Given this list of marker genes PPP1R1B, LINC02038, FGF20, SFTPA2, PGC, NOTUM, SFTPA1, LINC01331, ENG, CLDN2, AQP1, ADH1C, C11orf96, C10orf90, RASGRF1, CEMIP, DLG2, FMN1, KCNJ5, CDH16, SHISA2, CD36, MGLL, TMEM163, ADORA1, NAPSA, TNC, COL6A3, ASPG, ACOXL, C16orf74, here is a description of the gene set: from publication He P, Lim K, Sun D, Pett JP, Jeng Q, Polanski K, Dong Z, Bolt L, Richardson L, Mamanova L, Dabrowska M, Wilbrey-Clark A, Madissoon E, Tuong ZK, Dann E, Suo C, Goh I, Yoshida M, Nikolić MZ, Janes SM, He X, Barker RA, Teichmann SA, Marioni JC, Meyer KB, Rawlins EL (PMID 36493756) species: Homo sapiens Human Gene Set: HE_LIM_SUN_FETAL_LUNG_C1_LATE_TIP_CELL Late tip